The following is a description of a gene set: Human Gene Set: HSF_Q6 studied in species Homo sapiens Genes having at least one occurrence of the motif TTCCMGARGYTTC in the regions spanning 4 kb centered on their transcription starting sites. This matches the transcription factor binding site V$HSF_Q6 (v7.4 TRANSFAC)., and this is the list of marker genes: ZNF428, RTN1, NAA50, MARCHF1, GPBP1, CACNA1G, ARHGEF38, ANKRD17, HSPA1A, PRG4, KLHL41, IL4, USPL1, TMEM256, TPI1P2, LRRK1, NCKAP5, DMRTB1, PIGV, MLLT3, KCNH5, PAX3 (NCBI Gene Id 5077), LGALS8, IL17RE, MAP3K3, C10orf88, CCDC140, AMPD2, PPP1R9B, ALKBH5, TNKS1BP1, ROBO1, STC1, FHL3, PPCDC, CSRP2, EDN1, DNAJB5, RBP5, HECTD4, C1RL, CPLX2, HSP90AB1, SHC1, MSX1, C8orf17, JOSD2, REM2, ATP2C1, TENT5A, SNAP25, GRM8, NNAT, RHOQ, GSN, RFX4, MID1IP1, BPIFA2, SLC4A10, RPL28, ITPRIPL1, UBE2K, PCSK1, C6orf62, MYOD1, GTF2A1, RELCH, FAM24B, SEMA6C (semaphorin 6C), ZBTB32, GABRQ, CCN1, CSRNP1, GATA6, CRYAB, NUTF2, LUC7L, ST13, OLFML3 (olfactomedin like 3), GRIA4, CHRM1, HSPB2, ATF3, MID1, LGI1, TLL1, PPID, STK3, RSPO2, MORF4L2, CNTN5, ZNF516-DT, AP1G2, DPF2, MAX, ATF2, HNRNPA2B1, LYRM1, CHURC1, SKIDA1, KLF14, INPP5E, KCNIP1, ATP8B4, CLSTN3, MARCHF6, CKS1B, GAS7, EIF4A2, KRT85, HSPA1B, PHF6, GEMIN4, IFT43, SIX4, WNK4, DCSTAMP, PLOD1, KCNK18 (potassium two pore domain channel subfamily K member 18), ACO2, SPIN1, DCUN1D3, JMJD6, ZBTB25, CYP46A1, PPP2R2A (NCBI Gene Id 5520), DALRD3, CCDC91, BCL6, NPPB, UBE2W, RCOR2, TNXB, ADCYAP1, CNNM1, YWHAG, BFSP2, COLCA1, HSPBP1, CALY, TMEM35A, CORO1A, PTOV1, ZNF541, TAF10, UBE2H, SIN3A (NCBI Gene Id 25942), TSACC, CD248, UBB, NFIA, ANK3, PRKAB1, XPNPEP3, RAI1, STAG2, CCT3, FSCB, GPHN, SH2D2A, P4HA1, TSC22D2, HSPD1, LYVE1, MYH14, PURA, JADE2, GRAMD2B, C12orf50, DNAJB1, ACOT7, FOXN1, UST (NCBI Gene Id 10090), MXRA8, ELAVL2, UCHL1, TSPAN17, PNCK, ZNF706, ZBTB37, IKZF2, PHF5A, ZFP69B, BAHD1, MAP6, LTBP1, HSPH1, TNPO3, FKBP4, GAD2, ZNF777, CREB3L2, ATP6V1A, TSPAN6, JPT2, NKX2-2, TNFAIP8, EIF1, ODAPH, HOXC4, HSPE1, CBX3, PTPRA, HSPA1L, MAP4K4, R3HDM2, HS6ST3, PSEN1, SERPINH1